The following is a description of a gene set: Intractable diarrhea studied in species Homo sapiens Human Gene Set: HP_INTRACTABLE_DIARRHEA, and this is the list of marker genes: SKIC3, PLEC, C5, EPCAM, SKIC2 (SKI2 subunit of superkiller complex), ITGB4, SMARCD2, SYK